Given this list of marker genes ZDHHC11B, SERINC3, USP18, HCFC2, OASL, PHB1, TMEM120A, PDE12, UBE2W, RIGI, TRIM31 (tripartite motif containing 31), MBL2, RNF135, TRAF6, USP20, TRIM6, EIF2AK2, RPSA, IFIT3, OAS1, DHX16, TRIM65, TRIM7, MARCHF2, USP44, IFIT2, CXCL10, PHB2, MORC3, HDAC6, STING1, ZBP1, NMBR, NCK1, DHX58, OAS3, NLRP1, MAVS, NMB, SERINC5, AKAP1, ZDHHC11, IRF3, UAP1, ATAD3A, TRIM21, IFIT1, TNF, RELA, DHX15, OAS2, IFIH1, NLRP6, TBK1, OTUD4, ZDHHC1, SENP7, UBE2N, SMARCA5, CARD8, DUS2, TRIM25, CLPB, UBL7, MX1, PRKRA, here is a description of the gene set: A defense response against viruses mediated through an innate immune response. An innate immune response is mediated by germline encoded components that directly recognize components of potential pathogens. Human Gene Set: GOBP_ANTIVIRAL_INNATE_IMMUNE_RESPONSE studied in species Homo sapiens